Given this list of marker genes TUBB, TUBA4A, KIF5C, TUBA8, TUBA3D, KLC1, BORCS5, KLC2, TUBB8, KIF5A, BORCS8, KLC4, TUBB4A, TUBA3E, KLC3, TUBA1C, TUBB6 (tubulin beta 6 class V), BORCS6, TUBB2A, BLOC1S1 (biogenesis of lysosomal organelles complex 1 subunit 1), TUBB3, SNAPIN, ARL8A, TUBA3C, BLOC1S2, PLEKHM2, TUBA1B, BORCS7, TUBB2B, TUBB1, TUBA1A, ARL8B, KXD1, TUBB4B, KIF5B, here is a description of the gene set: Human Gene Set: KEGG_MEDICUS_REFERENCE_ARL8_REGULATED_MICROTUBULE_PLUS_END_DIRECTED_TRANSPORT Arl8-regulated microtubule plus-end directed transport. Pathway ID: N01297. Pathway type: Reference. Pathway class: nt06125 Membrane trafficking (bacteria). species: Homo sapiens Pathway Definition from KEGG: BORCS == ARL8 == PLEKHM2 == (KIF5+KLC) == (TUBA+TUBB)